Given this list of marker genes RPL6, RPS6, RPS29, RPS28, RANBP2, NUP155, GRSF1, RPL35A, POLR2K, CPSF4, RPS2 (NCBI Gene Id 6187), POLR2H, RPL26, RPL14, RPL17, KPNB1, RPS5, POLR2C, RPL23A, RPL37A, HSPA1A, RPL3L, RPS27L, RPL39, RPL11, RPL7, NUP54 (nucleoporin 54), RPL23, RPS25, RPL5, TPR, KPNA5, NUP35, RPS3, RPS18, RPL21, NUP98, RPL27A (ribosomal protein L27a), RPLP2, FAU, RPLP0, POLR2J, EIF2AK2, RPL18, POLR2D, NUP58, RPL36AL, POLR2E, NUP43, NUP62, RPS10, NUP205, RPL37 (ribosomal protein L37), RPS3A, POM121, RPS13, RPS8, DNAJC3, RPS12, KPNA3, NUP88, RPS16, RPL41 (NCBI Gene Id 6171), NUP85, NUP160, KPNA4, RPL3, AAAS, RPL31, NUP107, RPL36A, SEH1L, CANX, SLC25A6, RPL39L, RPS4Y2, RPS4Y1, RPL8, UBA52, RPS7, POLR2G, RPL38, POLR2F, ISG15, RPL7A, NUP37, RPL4, NUP214, GTF2F1, RPL10, KPNA1, RPL19, RPS11, PABPN1, POM121C, KPNA7, RPL9 (NCBI Gene Id 6133), NUP188, RPL10A, CLTC, RAE1, XPO1, POLR2I, HSP90AA1, RPL12, POLR2L, NUP93, RPL34, RPS17, RPS19, NUP50, NUP153, RPL35, CALR (calreticulin), RPSA, NUP42, RPS15A, RPL13, RPS27A, POLR2A (RNA polymerase II subunit A), RPL26L1, SEC13, RPL29, PARP1, RPL36, RPLP1, NDC1, RPS21, RAN, RPS14, RPL22L1, IPO5, RPL28, RPL32, CLTA, RPS27, RPL18A, NUP133, RPL10L, KPNA2, GTF2F2, RPS24, TGFB1, RPS20, RPL15, NUP210, RPL24, RPS15, POLR2B (NCBI Gene Id 7890), RPL13A, RPL27, RPL22, RPS26, RPS9, RPS23 (ribosomal protein S23), RPL30, RPS4X, here is a description of the gene set: Influenza Infection Human Gene Set: REACTOME_INFLUENZA_INFECTION species: Homo sapiens